Given this list of marker genes Ppp1r9b, Adgrb3, Jph3, Prkn, Slc8a3, Synj1, Th, Ppp1r1b, Syt11 (synaptotagmin XI), Braf, Adrb2, Ctns, Deaf1, Kalrn, Ap1s2, Brsk1, Abl2, Clstn2, Npas4, Clstn3, Jph4, Agt, Abca7, Ntrk2, Slc6a4, Jun, Drd1, Git1, Atad1, Itgb1, Slc7a11, Reln, Pak6, Rag1, B3gat1, Ric8a, Bdnf, Nps, Nrxn1, Grin1, Pianp, Lgmn, Tnr, Rapgef3, Oprk1, Oprl1, Epm2a, Grm5, Dbh, Ddhd2 (NCBI Gene Id 72108), Atp8a1, Ckap5, Ptgs1, Adra1b, B4galt2, Shank2, Grm4, Atxn1, Gucy2d, Drd4, Mtor (mechanistic target of rapamycin kinase), Mup20, Aaas, Hrh3, Dcdc2a, Grin2b (NCBI Gene Id 14812), Grm7, C1ql1, Pde1b, Pgrmc1, Tac1, Pde8b, Shank3, Cck, Ttc36, Htr6, Gabra5, Abcc8, Foxb1, Adcy3, Srf (serum response factor), Arf4, Hif1a, Drd3, Snap25, Sct, Rin1, Htr2a, Neto1, Aldh1a7, Pak5, Pln, Asic1, Tacr2, Nlgn3, Drd5, Kcnq2, Ndrg4, Cacna1c, Nptn, Rgs14, Ift20, Nf1, Amph, Chrna7 (NCBI Gene Id 11441), Gpr88, Meis2, Atp1a3, Creb1, Htt, Htr2c, Eif2ak4, Fgf13, Tsc1, Sgk1, Ephb2, Ptgs2, Dgki, Cln3, En1, Ctnnd2, Comt (catechol-O-methyltransferase), Mapk8ip2, Tlr2 (toll-like receptor 2), Nrxn3, Gmfb, Slc1a1, Tbr1, Zzef1, Nrxn2, Mecp2, Kras (Kirsten rat sarcoma viral oncogene homolog), Nfix, Plcb1, Pak1, Grin2a, Glp1r, Atp1a2, Arc, Tpbg, Elavl4, Crhr1, Foxp2, Cdk5, Tafa2, Chrnb2, Kmt2a, Ube3a, Ptn, Drd2, App, Cntnap2, Cic, Lrrn4, Neurod2, Btg2, Dkk1, Nts, Shank1, Gabrb3, Vdac3, Stra6, Csmd1 (CUB and Sushi multiple domains 1), Bche, Synpo (synaptopodin), Ucn, Uba6, Cacna1e, Tanc1, Pias1, Nptx2, Cln8, Tacr1, Prkar2b, Gria1, Hmgcr, D130043K22Rik, Ghrl (ghrelin), Ntsr1, Taco1, Hrh2, Syngap1, Ppt1, Ythdf1, Slc24a2, Idua, Fos, Slc6a1, Map1a (microtubule-associated protein 1 A), Kit, Abl1, Fosl1, Vdac1, Cntn2, Slc8a2, Chrd, Hrh1, Sorcs3, Slc12a5, Adam2, Atxn1l, Tuba1a, Specc1, Crh, Chst10, Nog, here is a description of the gene set: Mouse Gene Set: GOBP_LEARNING species: Mus musculus Any process in an organism in which a relatively long-lasting adaptive behavioral change occurs as the result of experience.